The following is a description of a gene set: This event has been computationally inferred from an event that has been demonstrated in another species.<p>The inference is based on the homology mapping from PANTHER. Briefly, reactions for which all involved PhysicalEntities (in input, output and catalyst) have a mapped orthologue/paralogue (for complexes at least 75% of components must have a mapping) are inferred to the other species. part of: Transport of small molecules electronically inferred by orthology from the curated human pathway species: Mus musculus Reactome Pathway: Intracellular oxygen transport, and this is the list of marker genes: Ngb